Given this list of marker genes DRG1, SSBP1, PSMG1, NDUFAF1, RSPH3, HTATIP2, SMN1, REX1BD, CPSF4, RRM2, ELOF1, ARL5A, PRDX1, PRELID1, UQCC2, RAB1A, ANKRD40 (NCBI Gene Id 91369), PDIA6, TIMM8B, TMPO, PSMA7, S100PBP, POLD1, NOP16, AHCY, TOPBP1, RUVBL2, EIF2B5, PFKL, ETF1, ZRANB2, GPN2, HSPA9, PRDX2 (peroxiredoxin 2), TFDP1, METAP1 (methionyl aminopeptidase 1), PDAP1, THUMPD3 (THUMP domain containing 3), DBI, NCAPH2, PGRMC1 (NCBI Gene Id 10857), PRPF31, COPS7A, BSG, SLC25A17, EIF3B, MCM10, LRRC59, STMN1, GARS1, PGD, FASN, REEP5, IFRD2, BANF1, MRPS33, COA3, PSMA5, TIMM13, ACP1, PSMD1, SNRNP40, PRC1, SEC23B, UBE2T, COQ7, MRPL12, GNPAT, CDC6, LSM3, ANAPC4, DPY30, ECT2, HSPA4, PIGF, PABPC4, ITPA, HNRNPLL, CDK4, SELENOH, PSMB7, NUP93, UBE2M, PSMD5, UBE2S, ACOT9, DTYMK, KIF11, MANF, OXCT1, EZH2, EIF2B1, CCNC, SMC2, NUP62, CCNF, TNPO3, NASP, LONP1, SFXN1, PSAT1, FARSA, CENPC, SEC13 (SEC13 homolog, nuclear pore and COPII coat complex component), TARDBP, XPO1, LSM2, ATP5IF1, GPN1, KPNA2, MRPS25, G6PD, NDUFB7, DNAJB1, MTERF2, SSR2, YBX3, UQCR11, HMGN5, GSPT1, MTCH2, TRIM59, ZNHIT1, FDX1, EXOSC10, EIF6, DYNLL2, H2AX, DDT, MRPL27, MRPL35, MARCKSL1, SSNA1, NANS (NCBI Gene Id 54187), CUL2, MTHFD2, NDUFA8, EXOSC7, PSMD7, PLRG1 (pleiotropic regulator 1), CD9, ASF1A, PRDX4, PGK1, PEBP1, CDC34, ABCE1 (ATP binding cassette subfamily E member 1), CDC123, MRPS12, SAR1B, CAPG, KIF22, PPP1R7, RNPS1, HSPD1, HAT1, NUBP1, COX17, ALDOA, PHF5A, MAD2L1, IPO11, CDC16, RRM1, VPS26C, CDC45, PRDX3, NCAPH, SS18L2, CLPP, GART, MRPL13, PSMA4, OGT, PHF23, DPP3, PSMA1, MRPL51, PSMC1, MRPL11, RBMXL1, UBFD1, PDCL3, ASPM, DTL, ARL1, TMEM208, TTK (TTK protein kinase), MCM7, ABCF1, HMGB2 (high mobility group box 2), SKIC8, STOML2, LITAF, HSPA14, FAM98A, POLD2, PKM, UBAC1, NUTF2, here is a description of the gene set: species: Homo sapiens Differentiation of naive CD8 T cells into cytotoxic effector cells requires three distinct signals- antigen (signal 1), costimulation -B7-1 (signal 2) and cytokine, either interleukin-12 or interferon-a/b (signal 3). Interaction of naive CD8 T cells with antigen and B7-1 programs cell division and proliferation whereas the presence of cytokines- IL-12 or IFNa/b promote survival, differentiation and memory establishment. In the absence of signal 3, the cells interacting with antigen/B7-1 undergo tolerance induction. The objective of this study was to elucidate the mechanisms how the provision of signal 3 promotes differentiation and averts tolerance induction in CD8 T cells. Trichostatin A is a pharmacological agent that inhibits histone deacetylase activity, hence regulating chromatin structure and gene expression and differentiation in many cell types. Gene signature profiles of IL-12, IFNa/b and trichostatin A stimulated cells were compared to elucidate the molecular mechanisms of gene regulation. Oligonucleotide microarray analysis is carried out to determine the extent and molecular nature of the CD8 T cell differentiation program induced by IL-12 or IFNa/b in concert with antigen and B7-1 signal. from publication Agarwal P, Raghavan A, Nandiwada SL, Curtsinger JM, Bohjanen PR, Mueller DL, Mescher MF (PMID 19592655) Genes down-regulated in comparison of CD8 T cells at 0 h versus those at 48 h. Human Gene Set: GSE15930_NAIVE_VS_48H_IN_VITRO_STIM_CD8_TCELL_DN